Given this list of marker genes Gata6, Ckap5, Pcdh9, Sumo3, Cdca8, Pycr1, Kcnt2, Krt8, Igsf5, Cmc2, Slc7a2, Prmt7, Mycn, Galk1, Tbrg4, Gxylt2, Vash2, Pa2g4, Tctn2, Dcn, Znrd2, Kantr, Rangrf, Hmmr, Ypel1 (yippee like 1), Hunk, Mcm5, Ipo13, Greb1 (gene regulated by estrogen in breast cancer protein), Rack1, Anapc15, Sox11, Suv39h1, Elp5, Fap, Bzw2, Efs, Adcy2, Zcchc18, Prim1, B4galt2, Pih1d1, Rad18, Rnf227, Celsr1, Lmnb2, Fkbp4, Zfpm2, Lrfn4, Gm47342, Tgfb3, Grip1, Pold2, Lsm4, Selenow, Tmem231, Sgta, Bmp5, Dync2i2, Prnp, Dtl, Hspbp1, Cdt1, Arsb, Col3a1, Nlgn2, Epha4, Agtr2, Gli3, Homer2, Ttl, Prdx6, Zmiz1, Cad, Zfp692, Zfp593 (NCBI Gene Id 68040), Cenpk, Soat1, Ecm1, Cenpx (centromere protein X), Hnrnpu, Lsm3, Comp, Lama4, Nipsnap1, Firrm (NCBI Gene Id 381306), Mir100hg, Nkd1, Cd276, Knstrn, Cenpv (NCBI Gene Id 73139), Syce2, Ccnd2, Abhd14a, Mxd3, Tmem151b, Ccn4, Nt5dc2, Tyms, Srl, Mmp16, Cdca5 (NCBI Gene Id 98161), Ccdc88c, Clstn2, Aspm, Mcm3, Hmgxb4, Cdh6, Camsap3, Pole3, Ncam1, Tmem132a, Dctpp1, Rtl6 (retrotransposon Gag like 6), Emc8 (ER membrane protein complex subunit 8), Cftr, Plch1, Ar, Cldn6, Pcbp4, Adamts2, Asap1, Ccnb2, Cadps2, Phgdh, Dcakd, Celf4 (CUGBP, Elav-like family member 4), Spsb4, 6330403K07Rik, 4930426D05Rik, Fkbp10, Amer2, Epb41l4a, Pals2, Nsl1, C030006K11Rik, Lgi2, Morn2, Ube2t, Cdc45 (NCBI Gene Id 12544), Rad51, Smc1a, Fbln7, Reln, Clu, Aprt, 3000002C10Rik, Gprasp2, Ube2c, Nuf2, Taf6l, Papss2, Cdca3, Ptn (NCBI Gene Id 19242), Ankrd54, Pdlim4, Fn1, Ska3, Flywch1, Srpx, Rcc2, Igsf8, Ccdc80, Cthrc1, Ndufb7, Sipa1l1, Lsp1, Cpxm1, Bmper, Exosc8, Skp2, Sbk1, Incenp, Cyba, Faxc, 2610307P16Rik, Plet1 (NCBI Gene Id 76509), Mcm7, Macrod1, Ednra, Pdgfa, Stard10, Prdx2, Gas6, Tacc3, Tmem238, Antxr1, 2310011J03Rik (RIKEN cDNA 2310011J03 gene), Fras1, D17H6S56E-5, Cxxc4, Utp15, Pold1, Cenpa, Apex1, Tgfbi, Six2 (NCBI Gene Id 20472, sine oculis-related homeobox 2), Cdca7l, Palm, Pin1, Lsr, Clec11a (NCBI Gene Id 20256), Phactr1, Cdk2ap1, Map3k21, Hoxa11os, Pycr3 (pyrroline-5-carboxylate reductase 3), A930004J17Rik, Elapor1, Apcdd1, Tnfaip6, Gja1, Cbx5, Mif, Slc38a1, Mrps27, Pttg1 (NCBI Gene Id 98125), Cd79b, Gria3, Hoxb6, Apbb1, Nphp1, Fat3, 9430078K24Rik, Sertad4, Bex2, Uhrf1, Mgp, Il33, Wnt4, Boc, Atp1a2, Pamr1, Sall2, Rnaseh2c, Nme1, Cndp2, Snrnp70, Ugt2b34, Bok, Klf5, Cadm1, Igf1, Lmnb1, Hdac11, Cldn9, Mns1, Dipk1b, Pafah1b3, Fxn, Ppan, Dnajc9, Lama2, Banf1 (NCBI Gene Id 98145), Krt18, Adamts20, Cyp1b1, Cks1b, Trpm4, Hmgb3, Fbln5, Lum, H13, Socs2, Syne2, Car4, Abhd16a, Unc119 (unc-119 lipid binding chaperone), Tspan33, Vps37d, Mtmr7, Mmp11, Snora65, Colec11, Atp23, Fcgrt, Glrb, Tmsb15l, Nfix, Lypd6b, Ncaph2, Atad3a, Hoxb5os, Rrp1b, 2610005L07Rik, Tpx2 (NCBI Gene Id 72119), Oscp1, Noc4l, Adipor2, Psat1, Snap91, Meg3 (maternally expressed 3), Bnc2, Mettl1, Nfia, Rpl41, C1ql1, Ptgds, Exosc5, Pcdh8, Pfkl, Ranbp1, Hs6st2, Cdk1, Mex3a, Slc4a3 (NCBI Gene Id 77824), Relt, Bmp4, Ccna2, Nfatc4, Akr7a5, Wfdc2, Fam185a, Aldh18a1, Tmem97, Mir99ahg (Mir99a and Mirlet7c-1 host gene (non-protein coding)), Smchd1, Tmem176b, Sema3c, Mrto4, Kcnk5, Dnah1, Chaf1b, Rcn3, Ncaph, Cpne5, Alcam (activated leukocyte cell adhesion molecule), Kcp, Grwd1, Msi1, Aldh16a1, Ppa1, Actb, Dtymk, Cdc25c, Mir17hg, Evc2, Srd5a1, Hmga2, Slit2 (slit guidance ligand 2), Xrcc1, Espl1, Trappc6a, Gas2l3 (growth arrest-specific 2 like 3), Cyp7b1, 1110038B12Rik, Mdk, Emg1, Entrep1, Rps9, Serpinf1, Bcl7a, Abhd11, Col1a1, Mapkapk3 (mitogen-activated protein kinase-activated protein kinase 3), Igdcc4, Vcan, Iqgap3, Patz1, Dclk1, Eya1, Fndc4 (NCBI Gene Id 80564), Mfap2, Mrpl9, Pgap2, Kcnd3, Lhx1os, Gstt2, Misp, Bri3bp, Cdkn1b, Kif22, Nrp2, Prkar1b, Postn, Atic, Knl1, Ppp1r14b, Lgals1, Snrpb, Hells, Dscc1, Selenoh, Tead2, Rhou, Capn6 (NCBI Gene Id 12338), Keg1, Rbfox3, C1qtnf12, Parm1, Clcn2 (NCBI Gene Id 404589), Vps72, Spon1, Tet1, Nr2f2, Cd38, Blm, Kntc1, Rhebl1, Islr, Timeless, H2-DMa, Col6a1, Gpc6, Rab17, Etv5, Thop1, Spc24, Srm, Lhfpl2, Tk1, Pltp, Vcam1, Matn2 (matrilin 2), Penk, Rpsa, Pimreg, Phb1, Dgcr6, Guk1, Neurl1a, Rbp1, Cfh, Wnt8b, Sesn2, Lrrc56, Stmn1, Rfc3, Pax8, Cdca7, Gnasas1, Eef1akmt4, Esr1, Ace2, Lbp, Meis1, Col6a2, Maoa, 5033421B08Rik, Hjurp, Hnrnpr, Igfbp2, Tgm2, Echdc2, Fmod, Gm30124, Spint1, Col8a2, Rgs17, here is a description of the gene set: Mouse Gene Set: CUI_TCF21_TARGETS_2_UP from publication Cui S, Li C, Ema M, Weinstein J, Quaggin SE (PMID 16207825) studied in species Mus musculus Mouse mutations have provided tremendous insights into the molecular basis of renal and glomerular development. However, genes often play important roles during multiple stages of nephrogenesis, making it difficult to determine the role of a gene in a specific cell lineage such as the podocyte. Conditional gene targeting and chimeric analysis are two possible approaches to dissect the function of genes in specific cell populations. However, these are labor-intensive and costly and require the generation, validation, and analysis of additional transgenic lines. For overcoming these shortcomings and, specifically, for studying the role of gene function in developing glomeruli, a technique to isolate and purify glomeruli from murine embryos was developed. Combined with gene expression profiling, this method was used to identify differentially expressed genes in glomeruli from Pod1 knockout (KO) mice that die in the perinatal period with multiple renal defects. Glomeruli from early developing stages (late S-shape/early capillary loop) onward can be isolated successfully from wild-type and KO kidneys at 18.5 d postcoitus, and RNA can readily be obtained and used for genome-wide microarray analysis. With this approach, genes that are differently expressed between glomeruli from Pod1 KO and wild-type mice were identified, including a four-fold reduction of alpha 8 integrin mRNA in glomeruli from Pod1 KO mice that was confirmed by immunostaining. This procedure may be adapted to any transgenic strain, providing a rapid and efficient method to dissect the function of specific genes in glomerular development. All significantly up-regulated genes in kidney glomeruli isolated from TCF21 knockout mice.